Given this list of marker genes Grem1, Fpr-rs6, Lyn, Ninj1 (ninjurin 1), Aif1, Cxcl10, Dusp1 (dual specificity phosphatase 1), Fpr2, Nbl1, Ccr1, Lgmn, Cxcl17, Ccl2, Tnfsf18, Ccl5, Fpr-rs7, Ccl1, Creb3, Fpr-rs4, Pla2g7, S100a14, Mospd2, Fpr-rs3, Serpine1, Ccn3, Ano6, Slit2, Slamf8, Ccr1l1, Cxcl12, Cx3cr1, App (amyloid beta precursor protein), Ccr2, Defb25, Hmgb1, here is a description of the gene set: studied in species Mus musculus Any process that modulates the frequency, rate, or extent of monocyte chemotaxis. Mouse Gene Set: GOBP_REGULATION_OF_MONOCYTE_CHEMOTAXIS